The following is a description of a gene set: species: Homo sapiens from publication Gargalovic PS, Imura M, Zhang B, Gharavi NM, Clark MJ, Pagnon J, Yang WP, He A, Truong A, Patel S, Nelson SF, Horvath S, Berliner JA, Kirchgessner TG, Lusis AJ (PMID 16912112) Human Gene Set: GARGALOVIC_RESPONSE_TO_OXIDIZED_PHOSPHOLIPIDS_TAN_DN Genes from the tan module which are dn-regulated in HAEC cells (primary aortic endothelium) after exposure to the oxidized 1-palmitoyl-2-arachidonyl-sn-3-glycerophosphorylcholine (oxPAPC). Oxidized phospholipids are thought to promote atherogenesis by stimulating endothelial cells (ECs) to produce inflammatory cytokines, such as IL-8. In studies with mouse models, we previously demonstrated that genetic variation in inflammatory responses of endothelial cells to oxidized lipids contributes importantly to atherosclerosis susceptibility. We now show that similar variations occur in cultured aortic ECs derived from multiple heart transplant donors. These variations were stably maintained between passages and, thus, reflect either genetic or epigenetic regulatory differences. Expression array analysis of aortic EC cultures derived from 12 individuals revealed that >genes were regulated by oxidized phospholipids. We have used the observed variations in the sampled population to construct a gene coexpression network comprised of 15 modules of highly connected genes. We show that several identified modules are significantly enriched in genes for known pathways and confirm a module enriched for unfolded protein response (UPR) genes using siRNA and the UPR inducer tunicamycin. On the basis of the constructed network, we predicted that a gene of unknown function (MGC4504) present in the UPR module is a target for UPR transcriptional activator ATF4. Our data also indicate that IL-8 is present in the UPR module and is regulated, in part, by the UPR. We validate these by using siRNA. In conclusion, we show that interindividual variability can be used to group genes into pathways and predict gene-gene regulatory relationships, thus identifying targets potentially involved in susceptibility to common diseases such as atherosclerosis., and this is the list of marker genes: FN1, EFNB2, EXT1, SOX4, SLC35D1, CCDC9B, NUAK1, PLD1, DCBLD1, NAV1, LINC00581, ENC1